Given this list of marker genes TTC4, NDST1 (NCBI Gene Id 3340), PPIP5K2, CHMP2B, PCDHGC3 (NCBI Gene Id 94378), TRIP12, MMP9, KDM6B, EXT1, BRWD3, BCL2L2, GMFB, CAVIN3, CEP170, P2RY11, MCU, RHOB, ALDH3B1 (aldehyde dehydrogenase 3 family member B1), BCL10, VMP1, NR4A2, TIGD3, DHX8, NRROS, FKBP9, DNM2, COTL1, NCF1C, MTMR14, TICAM2, USP3, FBN1, SSPN, PIP5K1B, NRARP, GUCY2D (NCBI Gene Id 8145), BCL2A1, SAP130, CARM1 (NCBI Gene Id 10498), NT5DC2, DUSP10, PGAM2, UBALD1, RUSC2, AP3B1, WDR45B, IGF2BP2, SLC38A9, FEM1A, COQ8A, ZFP92, SLC38A7, SPOPL, NIPSNAP2, KLF4, FAM110B, PSMD11, NADK, ATF3, UAP1L1, JDP2, LYST, MAT2A, USP8, PELI2, HDC, PNOC, FAAP24, SPI1, ID2, CD86, RFX1 (regulatory factor X1), OSR2, RAB5C, CDK14, SHKBP1, CAPZA1, EIF4G2, MFSD2A, RAB5A, ADAM17, RIPK2, DACH1, SLC35E3, TLR6, SLC2A6, SMTN, MARVELD1, VPS26A (NCBI Gene Id 96725), SCAMP2, EPHX3, HYCC1, P2RX1, IRF8, KCNC3, DPPA4, ADRM1, NUP58, IFT20, MBTPS2, CENPW, FOSL1, CCDC88A, ANGPT1, PHACTR1, P2RY1, ARHGAP1, GBGT1, TKT, ARHGAP23, MYO5A, MIS18BP1, FAM222A, CCSAP, IL1R1, RNASET2, RAD51AP1, SPHK1, ROCK1, CYC1, CASP9, BAG6, ACTMAP, MOB1A, LIN7A, DDX21, GEN1, ZNF503-AS2, ARL8B, TNFRSF21, GPER1, AZU1, SIRPB2, TNFSF13, CLEC4F, THG1L, RILPL2, KSR1, CYB5R4, DENND10, SIPA1L3, P2RY13, YPEL2, GLTPD2, OCRL, CCNYL1, TNFRSF12A, ABHD5, DOCK4, MIDEAS (NCBI Gene Id 91748), SLC12A3, KPNA3, ING3, KLHL2, HRH2, MED14, CLEC4D, ZNF689, LACTB, RAB1A, RNASEK, ALAS1, PPP2R5B, SMARCD3, MRPS17, C15orf48, ACVR1B, IER5 (NCBI Gene Id 51278), IRS2, TUBGCP2, WASF1, SRGN, MAPK8, CLEC12A, ZNF385A, RIT1, GNAQ, DOCK8-AS1, ARL6IP1, RNF122, MTHFD2, ARID3A, SBF2, MAP1LC3B2, LILRB1, MAP3K11, ZNF614, BLTP3B, CSF3R, TBC1D8, LILRB4, EIF4EBP1, TMEM175, IRAG2 (NCBI Gene Id 650574), MAN1A1, STK32B, DDO, COL24A1 (NCBI Gene Id 255631), LDLRAD3, ST14, RASL11A, OSGIN2, SERPINB1, P3H2, UBE2W, BHLHE41, FSCN1, TFE3, GOLIM4, SFT2D2, TMEM170B, SMCO4, CLMN, MDM2, BCL2L11, SNX12, PNPLA2, CLDN23, HLA-DMB, MYO1E, MAPK7, PLPP3, COX5B, IQGAP2, PTGES, CYRIA, MAP3K3, NAT8L, CDC42BPB, GNA11, FCN1, ALDH2, GNG5, TNFAIP6, JAK2 (Janus kinase 2), NFKBIE, NRBF2, DSG2, MFAP1, VRK2, MTX1, SNX29, VPS37C, EMP1, JARID2, SLC22A18, SLC49A4, HMOX1, GINM1, RBBP8, DLX2, CD80, KATNIP, GAB2, MAP2K7, TXNDC5, CEBPB, ETS2, FAM117B, AP2A1, BCAT1, ZNF844, H3-5, SLC16A5, HAL, TBC1D2, SCRN1, SGK1, MAPK6 (NCBI Gene Id 5597), SPRTN (NCBI Gene Id 83932), SCARF1 (NCBI Gene Id 8578), CHST15, TESK2, TLR1, LILRA4, RASL10A, JUND, IQSEC2, PICALM (phosphatidylinositol binding clathrin assembly protein), CA5BP1, MPEG1, PLAUR, HERPUD1, FCHSD2, PNPLA8, GRINA, JUN, LRRC4, UGCG, BNIP3L, STEAP3, BZW1, HSPG2, FGD6, STK17B, CHMP1B, PHAF1 (phagosome assembly factor 1), OLR1, GZF1, KAT5, ITPRID2, MTMR6 (myotubularin related protein 6), XXYLT1, PMAIP1, HES1, INSR, DERA, GPR18, DNAJC11, MTMR10, IMPA2, ECHDC3, RARA, ARL4A, NPR3, NFIL3, P2RX7, BCL6, FOXO3, RAB20, HIP1 (NCBI Gene Id 3092), PFKFB3, OPN3, KCTD5, SAPCD2, KIAA0513, AHR, NAMPT, KIF13A, SAP30 (Sin3A associated protein 30), CKS2, TLR4, TMEM167B (transmembrane protein 167B), ABAT, FLII, CXCL16, PTX3, KANK2, NCKAP1L, SGK3, PLXND1, LDHD, ZMYND15, PGM5, TMEM86A (NCBI Gene Id 144110), NFIC, TRIM26, CORO7-PAM16, MAPRE3, TNFSF15, INO80B, TBXAS1, PYCARD, AKIRIN2, TREML4, CPA3, GABARAPL1, ZBTB21, RAB18, ARL8A, YTHDF3, PDLIM7, MEX3B, MAN2B1, NCF2, MAPRE1, CORO1C, PLAGL2, ZBTB34, LILRA1, SCARB2, HSPA13, NFKBIB, ELL, SIGLEC6, CCDC6, PXDC1, ATOX1, UVSSA, PNPLA1, TNS3, MGRN1, MIR24-2, CHKA, RAB35 (RAB35, member RAS oncogene family), MED29, DCUN1D3, SLC30A1, RRBP1, FEZ2, SLC39A9, PTPRS, PRLR, CMIP, FOSB, FRRS1, FAM53C, MPO, TUBGCP3, DSE, PILRA, USP6NL, EVI2B, NIPAL2, CDC5L, RRP12, ARF4, SLC19A2, C4orf46, GTF2B, ENTPD7, DYM, RAB8A, SWAP70, PIK3CG, MYO1F, KLF10, CBX6 (NCBI Gene Id 23466), INCENP, SLC9A7, CSGALNACT2, DNAJC3, IER2 (NCBI Gene Id 9592), FNDC3B, FAM91A1, TMEM88, KLHL8, PRKACG, GJB2, PRMT3, MOB3A, GNB4, WDR47, BAMBI (BMP and activin membrane bound inhibitor), SEMA7A, HLA-DRB1, MERTK, SMAD1, NCOR2, SYT1, NATD1, SCN9A, ARF1, TENT5B, ZNF697, ZMIZ1, BAHCC1, MKNK2, SKAP2, KHSRP (KH-type splicing regulatory protein), C2orf49, NRP1, SRGAP2B, ARRDC4, GUCD1, RRAGC, ZC3H12A, DOCK5, ZNF124, SHANK1, PHLDA2, TSPYL5, PLEKHO2, IRF4, CDA, ATPAF2, SLC30A9, RAD9B, ZC3H12C, HIF1A, NLRP3, NR4A3, VAV2, CREB5, LINC02908, RBM47, C5AR1, ATP6V1F, TRIB1, MED25, HINT3, SCARB1, AIMP2, NAT1, TGFBI, VPS25, SQSTM1, HES4, KYNU, HAAO, CNIH4, SLC36A1, DDX49, OAF, BORCS8-MEF2B, NRAS, PIM3, ELF1, EMC6, ATP5F1B, BCL3, TNFSF12-TNFSF13, LRRC58, DAPK1 (NCBI Gene Id 1612), LYZ, TUBB3 (tubulin beta 3 class III), PLCG2, FCGR2C, NPEPL1, ZNF521, TMEM150B, MYO9B, MIDN, RGS2, MAP3K20 (NCBI Gene Id 51784), CCDC86, NOTCH3, ANO8, TNFRSF1B, NOCT, CYP51A1, RIN3, RELT, NR4A1 (nuclear receptor subfamily 4 group A member 1), THEMIS2, LGALS8, GABARAPL3, SNIP1, CXCL8 (NCBI Gene Id 3576), SLC6A6, NCF1, CKAP2, IER3, GALNT2, QTRT2, MRPS22, PAK1IP1, SCAMP5, CCRL2, MPP7 (NCBI Gene Id 143098), CD38, STS, PFKFB2, APOM, YJU2, MID1IP1, UBE2D1, PLEK, ASAP1, ABCD1, MAP3K2, PAK4, EIF4E2, PANX2, TASL, WDFY4 (WDFY family member 4), EIF4A3 (NCBI Gene Id 9775), TP53INP2, MS4A14, ICAM1, TREM1, EPB41L2, UBE2E2, ACBD3 (NCBI Gene Id 64746), HBEGF, OLIG1, RASSF8, CUEDC1 (NCBI Gene Id 404093), ACP5, FFAR2, YWHAG, SGMS2, GPM6B, MIR3064, PGD, RAD23B (NCBI Gene Id 5887), PPM1L, TDG, WDR17, MAFK, RPS6KC1, ZFAT, BLTP3A, KLF2, THAP9, SOCS4, DCUN1D1, ADIPOR1, THBD, CTIF, BACH1, FRAT1, CD83, DLC1 (NCBI Gene Id 94517), SEMA4A, SNX13, PSMD3, MLX, ADM, ACSL4, ZFAND3, LIPN, SLC31A1, SLC7A11, TNFRSF10C, HS6ST1, GALNT3, ADGRE2, NFKBIA, TMEM154, MTMR3, VIM, SIGLEC14, PIGS, BAK1, FCGR3B, SERPINF1, TEKTIP1, CRACR2B, TOP1, MACC1, WASHC2A, ZNF710, SLC31A2 (solute carrier family 31 member 2), ID1, TSG101, SIGLEC15, ANKLE1, DENND1A, BRI3BP, TMEM38A, SOAT1, EEIG2, BMF, ITPRIPL2, F3, DVL3, TIMP2, CAT, IL1B, MED13L, LRRK1 (leucine rich repeat kinase 1), MKRN9P, RDX, MEF2A, RIPOR1, SLC22A4, CIMAP1C, EPHA2, NUDT3 (nudix hydrolase 3), CXXC5, SIPA1L2, ARG2, SAT1, POU2F2, ASAH1, TMEM255B, CNNM4, YWHAE, EIF3C, GPR141, ITPRIP, ZNF768, TAS1R3, HLX, TTLL4, SLC15A3, FCAR (Fc alpha receptor), ISG20L2, PEAK1, HIC2, SOX5, USP16, HDAC6, CD302, TIAM2, SFPQ, NUMB, KCTD3, SPTY2D1, PTP4A1, DOK3, ATP11A, NFE2L2, SHD, RNASE6, PPM1J, DOCK2, ALOX5, VNN1, FGD2, SIRT1, NADSYN1, ZNF746, NRIP1, SNX2, LYSMD3, NDEL1, USP38 (ubiquitin specific peptidase 38), SERPINB9, RB1CC1, CD300E, CCR1, DUSP6 (dual specificity phosphatase 6), SH3PXD2B, TGIF1, EIF4A1, RAB39A, GALR2, ZFP36 (NCBI Gene Id 7538), COL9A2, RSRC1 (NCBI Gene Id 51319), STX11, PLXDC2, GLUL, DCTN4, ELF4, SMARCB1, TMED7, EPN1, SFXN3, ITGAX, GAS7, AHNAK2, PXK, RNF130, STX16-NPEPL1, ATP2A2, ZDHHC7, PALD1, HLA-DMA, C15orf39, CTSZ, NAB2, TRAK1 (NCBI Gene Id 22906), PPP1R15A, CDC42EP2, HIC1, TBC1D23, LOXL3, MIR650, CEBPD, TMEM127, PTGS2, TMEM104, REEP4, CEACAM4, KIF5B, TUBB6, SLC25A37, TIFAB, RASGRP4, APP, HEYL, ZFTA, PLEKHM2, SRSF9, SOX15, LATS2, ABCA6, KPNA2, ZNF330, NHSL3, ANXA1, CCL20, TLNRD1, DDX3X, CADM4, STX12, TXNRD1, TICAM1, MXD1, C9orf72, AP5B1 (NCBI Gene Id 91056), CLEC4C, MAP3K20-AS1, MIR27A, ERG, EFCAB11, G0S2, C11orf96, SLC22A18AS, LTB4R2, CSF2RB, MEF2C, IQSEC1, AP1B1, SDCBP, GLA, SOD2, PLD2, MIER2, MITF, GAB1, CHML, AKT1S1, SLC25A34, CPEB4, SULF2, IDI1, ZNF532, DNASE1L1, MAFB (NCBI Gene Id 9935), MAML3, PTPRE, C19orf38, PNO1, RHOQ, TSPAN13, HSP90AA4P, LRRC59, TMED7-TICAM2, ZNF267 (zinc finger protein 267), TBC1D9B, EME2, YIF1A, DICER1, KBTBD7, PSMB7, ZNF281, CYBB, HNRNPH2, ITGA9 (integrin subunit alpha 9), EIF4EBP3, ABCA1, PPP2CA, GRK3, CBX2, KLF6, UBC, COBL, CLN6, CLPTM1 (NCBI Gene Id 1209), TTC7A, SIK1, SPIB, GRAMD1B, FTH1, RIOK3, TFIP11, IFIT2, HNRNPAB, PLK2, SIGLEC10, HLA-DRB5, GPRC5A, MTREX (NCBI Gene Id 23517), B9D2, GAS2L3, CMTM6, PI4K2A (phosphatidylinositol 4-kinase type 2 alpha), MIR23A, KREMEN1, ZFR, KLHL15, HMGCS1, CIDEB, VAMP3, ZFHX3, ABTB2, IDH3A, ZBTB43, OR2B11, CCDC103, PLPPR2 (NCBI Gene Id 64748), SH3RF1, CHRAC1, CD68, MAP3K8, PPIF, AZI2 (NCBI Gene Id 64343), GRAMD4, RPH3A, ST20-AS1, TRIO, SERPINE1, WASHC2C, HSPA4, ADGRA2, UNC93B1, MFAP3, TNRC18, NEDD9, RMND5A, RASD1, RGS7, MCL1, SESTD1, SEC14L1, SLX4, RRM2B, TBC1D12, TXNDC16, PLBD1, CBX8, SMPD3, BPI, MED12L, CLPB, SLC43A2, RAB11FIP1, SYK, TET3, OAT, C17orf107, RTL8C, C11orf24, RCOR1, OXER1, ACSL1, CD46, ADAMTSL4, SNX10, UBE2J1 (NCBI Gene Id 51632), DNMBP, FAM43A, IFNGR1, NUBP1, COA7, LASP1, LYNX1, LONRF1, LDLR, S1PR3, ADAM9 (NCBI Gene Id 8754), CRISPLD2, PRICKLE4, TRAM2, NAB1, GNL2, FTL, SOX4, YBX3, ARHGEF40, CIMAP1B, SEL1L, UGGT2, ITFG1, TNFRSF13C, NUDT17, BTBD3, CNTLN, FOSL2, OTUD1, MAFG, PCCA, KCNJ15, IPMK (inositol polyphosphate multikinase), SCAMP4, RIC1, MPV17L2 (MPV17 mitochondrial inner membrane protein like 2), FAM151B (NCBI Gene Id 167555), USP32, PELI1, ABRAXAS2, LGR4, KCNA5, MTCL2, INKA2, LHFPL2, ATOSB, TMEM39A, RP2, TFEC, GRN, PRC1 (NCBI Gene Id 9055), RELB, SETD7, VSIG10L, MILR1, CDC40, NR6A1, IL1RAP, AFF3, GMEB1, TBC1D9, NINJ1, RYBP, LRRK2, CLIP2, SPATA2L, DSC2, MICAL2, ZNF791, CCDC47, COBLL1, SYS1-DBNDD2, TMEM39B, LENG9, SLC36A4, PLAGL1, NHS, PISD, YPEL5, TSC22D2, HCAR2, STX10, MAP2K3, EIF4H, BCL2L2-PABPN1, MCM5, DENND3, EAF1, BAZ2B, NCF4, NFKBIZ, ARSG, MME, PIAS4, ZBTB7A, LRG1, CCDC43, ARHGAP42, LPCAT3, EIF3A, KCNJ2, ATF5, NFKBID, CERS6, ZNF703, RABGEF1, TRIM8, ALDH1A1, ALDH3B2, RPL7L1, DYSF, BMAL2, PLEKHM1, RREB1, RAF1, ZFAND5, ZNF184, SRC, ZBTB33, ID2B, SIN3B, NCOA4, IGF2BP3, RHBDF2, TNFAIP2, CASP3, NKIRAS2, WIPI1, SLC8A1, HMGXB4, CIITA, CD55, IFNGR2, ARHGAP24, TLE3, SIPA1L1, MCTP1, ELL2, SAMD4B, MUL1, RAP2C, BMP8B, KLK1, ATP6V0C, DPP3, NHLRC3, PLXNC1, BHLHE40, HMGCR, RHEX, DIAPH2, OGFRL1, SLC29A1, HBP1, GAPDH, FBXO30, GPR84, GAS6, ERCC5 (ERCC excision repair 5, endonuclease), GASK1B, OSGIN1, LY86, TTYH3, MYD88, IKBKG, PLVAP, CCNK, BASP1, NBPF10, SCIMP, MYADM, SLC19A1, GEM, VNN3P, ANP32D, LYN, ICOSLG, RNF24, CDC42EP4 (NCBI Gene Id 91740), TMTC2, PTTG1IP, GGN, RAB21, APLP2, SPRY2, ACAD9, TPK1, GUSB, RPP21, MNT, TUBB4B, ELOF1, CCDC50, JAG1, SOWAHC, SLC35B1, PRKACA, EREG, OASL, MROH1, GPX3, IGSF6, BLVRB, CD34, METRNL, ZNF516, BHLHA15, BANK1, DHTKD1, ARL5B, NSUN7, TENT5A, COP1, MFAP4, CKAP4, CDC42EP1 (CDC42 effector protein 1), B3GNT5 (UDP-GlcNAc:betaGal beta-1,3-N-acetylglucosaminyltransferase 5), SNAI1, ANKRD36BP1, PRXL2C, JADE3, DIPK2A, C5AR2, GPR27, TAF13, S100Z, CUX2, TET2, PLD4 (phospholipase D family member 4), FAM124B, GANC (NCBI Gene Id 2595), DOCK1, MON1B, CDKN1A, GSTP1, ATP6V0B, SERPINB2, TOR1AIP1, SLC17A9, PROSER1, KCNQ1, SLC1A5, TMEM144, VEGFA, TNFRSF10B, BTK, CWC25, SIDT2, TLR9 (toll like receptor 9), REL, BNIP2, ULK1, UCHL3, KRT23, CST3, STRN4, SLC35E4, HLA-DRA, CHRNE, PIK3R5, ESRRA, PPP1R15B, SKIL, ATP1B1, FEM1C, CSF1R, IL6, CCDC13 (coiled-coil domain containing 13), SSPOP, ZNF426, CLIC4, RAPGEF2, NR1H2 (nuclear receptor subfamily 1 group H member 2), DENND5B, ZNF100, TYROBP, NETO2, MED26, SLC2A3, TRAF7, CRK, TMEM167A, SERINC1, SH3BP4, SCPEP1, ZNF594-DT, TMEM52B, RSC1A1, ZNF593, FAM234A, HCAR3, KBTBD8, FRMD4B, CCPG1, IFI30, FOLR3, GNA15, WARS1, MAPK12, ADSS1, KDM4B, SLC7A5, SLC49A3, SERPINB8, GNAI2, PJA2, RASGEF1B, BOP1, ACO2, ST6GALNAC2 (NCBI Gene Id 6488), NANS, JMJD1C, FAM98B, FPR2, DOT1L, SH2B2, CERT1, IL17RC, TCF4, ETF1, ERF, LAMB3, KCNJ2-AS1, CBFA2T3, SLC12A6, OSM, ATP5F1C, SUSD6, TM9SF2 (transmembrane 9 superfamily member 2), FILIP1L, ZNF503, SESN2, RNF13, CSNK1A1L, SEMA6B, here is a description of the gene set: studied in species Homo sapiens Human Gene Set: HARALAMBIEVA_PBMC_FLUARIX_AGE_50_74YO_CORR_WITH_28D_MEM_B_CELL_RESPONSE_AT_28DY_POSITIVE from publication Haralambieva IH, Ovsyannikova IG, Kennedy RB, Zimmermann MT, Grill DE, Oberg AL, Poland GA (PMID 27317456) BACKGROUND: Studies suggest that the recall-based humoral immune responses to influenza A/H1N1 originates from activated memory B cells. The aim of this study was to identify baseline, early and late blood transcriptional signatures (in peripheral blood mononuclear cells/PBMCs) associated with memory B cell response following influenza vaccination. METHODS: We used pre- and post-vaccination mRNA-Seq transcriptional profiling on samples from 159 subjects (50-74years old) following receipt of seasonal trivalent influenza vaccine containing the A/California/7/2009/H1N1-like virus, and penalized regression modeling to identify associations with influenza A/H1N1-specific memory B cell ELISPOT response after vaccination. RESULTS: Genesets and genes (p-value range 7.92E(-08) to 0.00018, q-value range 0.00019-0.039) demonstrating significant associations (of gene expression levels) with memory B cell response suggest the importance of metabolic (cholesterol and lipid metabolism-related), cell migration/adhesion, MAP kinase, NF-kB cell signaling (chemokine/cytokine signaling) and transcriptional regulation gene signatures in the development of memory B cell response after influenza vaccination. CONCLUSION: Through an unbiased transcriptome-wide profiling approach, our study identified signatures of memory B cell response following influenza vaccination, highlighting the underappreciated role of metabolic changes (among the other immune function-related events) in the regulation of influenza vaccine-induced immune memory. Genes positively correlated with memory B cell response at 28d in peripheral blood mononuclear cell in seniors (50-74) after exposure to Fluarix, time point 28D